Given this list of marker genes ESYT1, ZKSCAN1, KIF1C, HNRNPA1, FGD1, DHCR24, CD48, KTN1, RBM17 (NCBI Gene Id 84991), AKAP9, RPS14, TRAF5, SURF6, MKNK2, SNAI2, TNIP1, PFKM, FAM118B, TEX2 (NCBI Gene Id 55852), HSP90AB1, HDAC5, MIPOL1, PHEX, RUFY3, IGF1 (NCBI Gene Id 3479), DHRS3, HSPA1B, EGR2, BTG3, VPS37A, IFIT3, WSB1, SIX1, ADRB2, TLX3, RASA3, TEC, CNR2 (NCBI Gene Id 1269), PEBP1 (NCBI Gene Id 5037), HEXA, SQSTM1, ACAA2, GSTM5, BCKDHA, DLX2, TTC27, IPP, NF1, IL12B, GKAP1, SLC6A13, PRKD3, DENND4C, ZNF622, SLC5A6, TPK1, APLP2, ELP3, SLPI, P3H3, RBM15, USP18, NVL, WASHC2A, FAM83F, LRRC8A, TRAF1, PAQR7 (progestin and adipoQ receptor family member 7), CXCL12, PON2 (paraoxonase 2), CDT1, BTG2, SERINC3, PAPSS2, IDH1, WDR45 (NCBI Gene Id 11152), CYB5A, ZFAND2A, RTN4, SFTPB, HSPA1A, SYT5, KIT, PPDPF, VHL, PRKCB, AP3D1, PRDX4, POU6F1, INPP5K, MAPK10, GLMP, CCNDBP1, CD28, ADAM8, PHLDB1, PRKCH, IGDCC3, FAM151A, ADIPOQ, PRKCD, STOM (NCBI Gene Id 2040), TNP2, MBP, MDM4, RYR3, ALDH7A1 (aldehyde dehydrogenase 7 family member A1), CPNE1, HTR1B, ROM1, NF2, PPEF2, CCN2, SCMH1, CACNA2D3, SMARCAD1, RAMP1, EPHX1, ZNHIT3, MRTFA, GDF9, BCL2A1, NELL2, MOS, EBI3, SMS, KLF2, LYL1, BRI3 (NCBI Gene Id 25798), SERPINF2, RUFY1 (RUN and FYVE domain containing 1), PCP4, SEMA4D, MATK, PIP4K2A, CSRP2, F9, MAN2B1, SGCA, DAP3, AGRN, CAPN2, MMP13, ALDH1A2, ACSS1, GPX3, SLC50A1, ANKRD13A, ANKH, CLIP1, TTC4, LSP1, GALT, KCNMA1, CBX4 (NCBI Gene Id 8535), IRF4, NDUFA9, MX1, SLC66A2, STK39, SFT2D1, CASK, ST3GAL5, ANXA4, CST3, UBE2R2, NUP50, RASA4, RPL32, RELL1, NME3 (NME/NM23 nucleoside diphosphate kinase 3), TMEM229B, ALDH9A1, OTUD7B, PPP1R21, FAM241A, ADCY9, PSMC4, NAXE, SERPINI1, BPHL, RRAGC, PSTPIP2 (NCBI Gene Id 9078), RIN2 (NCBI Gene Id 54453), ZNFX1, PLXND1, DEGS1, ATAD3A, HMGA2, RECK, PFN2, TFF2, TIMP3, SEMA3C, ZFPM1, HOXB9, MAP1LC3A, SLC6A12, LPCAT1, ACTN4, here is a description of the gene set: Genes up-regulated in memory CD8 T cells from brain: ITGAE- versus ITGAE+. from publication Wakim LM, Woodward-Davis A, Liu R, Hu Y, Villadangos J, Smyth G, Bevan MJ (PMID 22922816) Tissue resident memory (Trm) represent a newly described memory T cell population. We have previously characterized a population of Trm that persists within the brain following acute virus infection. Although capable of providing marked protection against a subsequent local challenge, brain Trm do not undergo recall expansion following dissociation from the tissue. Furthermore, these Trm do not depend on the same survival factors as the circulating memory T cell pool as assessed either in vivo or in vitro. To gain greater insight into this population of cells we compared the gene-expression profiles of Trm isolated from the brain to circulating memory T cells isolated from the spleen following an acute virus infection. Trm displayed altered expression of genes involved in chemotaxis, expressed a distinct set of transcription factors and overexpressed several inhibitory receptors. Cumulatively, these data indicates that Trm are a distinct memory T cell population disconnected from the circulating memory T cell pool and displaying a unique molecular signature which likely results in optimal survival and function within their local environment. studied in species Homo sapiens Human Gene Set: GSE39152_CD103_NEG_VS_POS_MEMORY_CD8_TCELL_UP